Given this list of marker genes Mtcl1, Cdk5r1, Vps37c, Zdhhc11, Zdhhc4, Chm, Srpra, Cemip (NCBI Gene Id 83495), Srp72, Pdzk1, Cdk5, Nacad, Slc51b, Zdhhc18, Zdhhc1, Itgb1bp1, Zdhhc19, Naca, Mief2, Grin2a (NCBI Gene Id 14811), Macf1, Zdhhc23, Srp54c, Micall1, Mff, Srp54a (NCBI Gene Id 24067), Sec61a1, Stom, Pard3, Get4 (NCBI Gene Id 67604), Hspa5, Ccl2, Golga7b, Sec61g, Vps37d, Itgam (integrin alpha M), Rab3ip, Arl6ip1, Gdi1, Kcne1, Zdhhc20, Kcnb1, Chp1, Akt2, Srprb, Arpc2, Vps37b, Pikfyve, Adora1, Fis1, C2cd5, Irgm2, Sec62, Zdhhc24, Sec61b, Cacnb1, Tcaf1, Chmp4b, Fyn, Actr3 (NCBI Gene Id 74117), Mief1 (mitochondrial elongation factor 1), Cib1, Exoc4, Zdhhc2, Ogt, Sec63, Zdhhc9, Rabgef1, Zfand2b, Ncf1, Slc1a1, Rtp2, Pak1, Folr2, Srp9, Sgta, Zdhhc6, Large1, Cacnb3, Get1 (guided entry of tail-anchored proteins factor 1), Aqp11, Rtp1, Sgtb, Zdhhc14, Zdhhc3, Sec61a2 (SEC61 translocon subunit alpha 2), Zdhhc25, Zdhhc7, Rtp3, Srp19, Zdhhc22, Golga7, Get3, Hpca, Dmtn, Dusp21, Srp14, Zdhhc21, Erbb2 (erb-b2 receptor tyrosine kinase 2), Tram1, Tram2, Zdhhc12, Ubl4a, Cacng2, Ank3, Usp17le, Ssr3, Tram1l1, Zdhhc15, Hras, Prnp, Myo1c, Inpp5k, Yif1b, Bag6, Srp68, Dusp18, Tent2, Folr1, Vps37a, Oga, Rtp4, Glp1r, Arl6, Cwh43, here is a description of the gene set: species: Mus musculus Mouse Gene Set: GOBP_PROTEIN_TARGETING_TO_MEMBRANE The process of directing proteins towards a membrane, usually using signals contained within the protein.